The following is a description of a gene set: studied in species Homo sapiens Human Gene Set: ZSCAN5B_TARGET_GENES from publication Yevshin I, Sharipov R, Kolmykov S, Kondrakhin Y, Kolpakov F (PMID 30445619), and this is the list of marker genes: SACM1L, PPEF1, RNU6-9, GARNL3, CFAP418, LINC02739 (NCBI Gene Id 105369317), PLXDC1, CCDC107, SHF, STAP2, LIMD1-AS1, MIR4521, RAB11A, MCRIP2, RNU6-2, ALOXE3, PRMT5-DT, METTL26, RN7SK, VTRNA1-2, MED16, PRMT5, RNASE11, RPS29, H4C8, RNY1, ILF2, GSTA4, RPPH1, ZNF839, LASP1, MYNN, DZANK1, HJV, MAP1LC3B, RNU6-1, NCOA7, RN7SL1, STK17A, DPP9, H3C9P, TRIM7-AS2, PPP6R3, KNL1, VTRNA2-1, SYPL1, PSMB3, POLG, FBXO31, POLG-DT, POLR3F, HSPA6, SMARCC2, NDUFS7, C2orf42, RNU6ATAC, RAD51AP2, LINC02136, LINC02453, TRIM41, GHET1, TIA1 (TIA1 cytotoxic granule associated RNA binding protein), TMEM259, BCAR3, NDC1, COX8CP1, POLR3E, B4GAT1, LINC01623, FMC1, RNY4, FMC1-LUC7L2 (NCBI Gene Id 100996928), LINC01556, B4GAT1-DT, ANG, SLC27A4, AGBL5-AS1, RNASE4, HMGN4, PARP2, AGBL5, VTRNA1-3, LRP3, LTA4H, HCG14, VTRNA1-1